Given this list of marker genes CLEC11A, ECE1, MEG3, COL4A1, RSRC2, DARS1, TCIM, ARL4D (ADP ribosylation factor like GTPase 4D), OAF, MALSU1, LAMP2, VCAM1, PPP1R12A, CTR9, CCN1, SPARC, RPL22L1, PRKAR1A, PSMA2, ZFAND5, DSEL (dermatan sulfate epimerase like), ZNF106 (zinc finger protein 106), SPON2, BGN, WLS, RPS7, PTMS, IP6K2, EMILIN1, SEC63, CACYBP, TSHZ2, ATP5F1C, ARID4B, DNAJA1, FSTL1, CLEC2B, HSPH1, CDH11, GRHPR, CCT2, ALDH9A1, PTTG1, APOE, PFDN4, TMOD3, COL1A2, NR2F2, COL5A1, MIR4435-2HG, FILIP1L, AHSA1, FRZB, ISOC1, RWDD4, C7, RPLP0, PLIN3, UBB, TLE1, NRP1, LANCL2, PTGER2, LDHB, FHL1, ZFAND2A, VGLL3, RPS26, TPM2, NME3, SERPINF1, GCLM, PPP1CC, EXTL2, MEST, FDX1, LGALS1, DYNLL1, IER2, LRRFIP2, PMP22, CAND1, RAD23B, EEF2, DLC1, ANKRD10, ARF6, EPS8, CLK1, COL3A1, RND3, MIF, RRBP1, TXNL1, HMGN2, PTK7, SCPEP1, PLTP, MAGED1, SLC25A5 (NCBI Gene Id 292), CKS2, RHBDD2, ATG101, NID2, ADH5, PEG3, F3, MTUS1, FAM210B, RCN1, SNHG25, OSR2, C19orf48P, ATP2B1, SPTBN1, IRF8, C5orf15, RHOBTB3, NR4A1, SERPINH1, NOLC1, MLF2, NME2, PPP2CA, S100A13, NUCKS1, COL6A3, ALDH1A1, KLHDC8A, NECTIN2, APOC1, RBM22, EIF3M, PLD3, ATP5MJ, C4BPB, DNAJB6, MYO6, PHLDA1, STAT1, PLOD1, LIMA1, STRAP, KLF4, ARF5, PXDN, U2AF1, ITM2C, HSDL2, NEXN, MDH2, LAMC1, GLRX, CSNK1A1, RBMS1, PPIA, TPM4, GLT8D2, HSPA8, TSPAN5, SRSF6, ATP6AP2, CLK4, PPIC, GBP4, COL15A1, P4HB, ISG15, PPP2CB, BORCS7, APEX1, COL4A2, CCNL1, FLYWCH2, LAMA4 (NCBI Gene Id 3910, laminin subunit alpha 4), EFEMP2, NID1, CYTOR, RCN2, NSG1, ACADVL, DDX5, SPG21, GCSH, SGCE, SNAI2 (snail family transcriptional repressor 2), APOD, PCOLCE, MTX2, THAP9-AS1, BAG3, GADD45G, OSTC, CHORDC1, ARHGAP5, ING1, MMP14, MCL1, ARL5B, CFAP20 (cilia and flagella associated protein 20), GLRX5, MRPL18, HNRNPA1L2, AKAP17A, JUN, COL6A2, ANGPTL4, ATP5MC3, MATN2, SDC2, NBEAL1, MMP2, RGS2, PTCH1, SAT2, MTDH, CCT4 (NCBI Gene Id 10575), OSER1, ARF4, MPG, PDGFRB, TAX1BP3, HNRNPA0, ATP5F1A, DNAJB4, NONO, ACAA1, COL18A1, EIF4A3, ATRX, HTRA3, COLEC11, EMP2, TMEM98, MORN2 (MORN repeat containing 2), LAMP5, UBC, NCALD, CALD1, SLC25A36, ECH1, IFI6, LAMB1, PBX1, KPNA2, GYPC, FERMT2, H2AC6, TCAF1, CTSC, CPXM1, SNHG19, SEPTIN7, WFDC1, IFITM3, TMEM9, SGK1, ZNF90, PGRMC1, CAT, SUSD3, JMJD1C, ADM, FKBP10, SEPTIN9, SRSF11, ENC1, NOP58, PFN2, TMEM45A, HACD3, CCN2, CHIC2, JMJD6, TMEM59, RASD1, TLE4, GADD45B, DDIT4, MYL12B, LAPTM4A, RBBP6, CITED2, HSPE1, UBXN4, RNASE1, GBP1, NPM3, TRIP6, COX6C, CALU, TPST1, COL6A1, HES1, MGARP, PPP3CA, IFITM1, TCP1, BOD1, SULF2, TTC3, RAB34, SCD5, TRA2B, PLAGL1, H2AZ1 (H2A.Z variant histone 1), COL1A1, LMAN1, C1orf52, KLF10, EGR1, TWSG1, CTSK, CPED1, PDGFRA, SDHD, AKIRIN2, SLC38A2, here is a description of the gene set: from publication Fan X, Bialecka M, Moustakas I, Lam E, Torrens-Juaneda V, Borggreven NV, Trouw L, Louwe LA, Pilgram GSK, Mei H, van der Westerlaken L, Chuva de Sousa Lopes SM (PMID 31320652) species: Homo sapiens TC from (healthy) follicles, such as follicles A, B, and C, were mainly clustered in CL5 (Fig. 4a), characterized by expression of known markers PTH1, APOD, APOC1, and several genes not earlier associated with TC, such as WFDC1, MATN2, COLEC11 (Fig. 7a). TC from the small antral follicles A and B did not overlap with TC from selectable follicle C in CL5 (Fig. 4a). Human Gene Set: FAN_OVARY_CL5_HEALTHY_SELECTABLE_FOLLICLE_THECAL_CELL